The following is a description of a gene set: part of: DNA Repair studied in species Mus musculus Reactome Pathway: DNA Damage Bypass electronically inferred by orthology from the curated human pathway This event has been computationally inferred from an event that has been demonstrated in another species.<p>The inference is based on the homology mapping from PANTHER. Briefly, reactions for which all involved PhysicalEntities (in input, output and catalyst) have a mapped orthologue/paralogue (for complexes at least 75% of components must have a mapping) are inferred to the other species., and this is the list of marker genes: Ufd1, Rfc1, Pold4, Pole, Rev3l, Ddb1, Usp43, Mad2l2, Poli, Pcna, Pold1, Rchy1, Rpa1, Ubb, Polk, Vcp, Rps27a, Pclaf, Uba7, Cul4a, Polh, Usp1, Sprtn, Rfc3, Cul4b, Dtl (NCBI Gene Id 76843), Wdr48, Pold2 (polymerase (DNA directed), delta 2, regulatory subunit), Pole2